Given this list of marker genes LTB4R2, CYSLTR2, LTB4R, GPR17, CYSLTR1, here is a description of the gene set: Reactome Pathway: Leukotriene receptors Leukotriene receptors bind leukotriene ligands. There are four types of receptor in humans; two for leukotriene B4 and two for cysteinyl leukotrienes (Brink C et al, 2003). part of: Eicosanoid ligand-binding receptors species: Homo sapiens